Given this list of marker genes BNC1, HLTF (NCBI Gene Id 6596), MYBL1, RAB25, PPARA (NCBI Gene Id 84730), NEUROD1, HOXC9, HOXD12, NEUROG1, NFIL3, VAX1 (NCBI Gene Id 196056), FOXC1, ANKRD1, HOXB3 (homeobox B3), HOXA3, HOXA6, ELF5, NFIA, NR4A2, DPPA2, VDR, EBF1, CLIP2, SIM2, RAB1A, HOXB4, SIX4, GCM2, MEF2B, HOXA13, MYF5, SMAD3, MEF2C, TRPC4, ID3, HNF1B, HMGA2, CUX1, here is a description of the gene set: Selected genes down-regulated in the TLX1 Tet On iEBHX15-4 cells (pro-erythroblasts) at 6 h time point. studied in species Mus musculus Aberrant expression of the human homeobox-containing proto-oncogene TLX1/HOX11 inhibits hematopoietic differentiation programs in a number of murine model systems. Here, we report the establishment of a murine erythroid progenitor cell line, iEBHX1S-4, developmentally arrested by regulatable TLX1 expression. Extinction of TLX1 expression released the iEBHX1S-4 differentiation block, allowing erythropoietin-dependent acquisition of erythroid markers and hemoglobin synthesis. Coordinated activation of erythroid transcriptional networks integrated by the acetyltransferase co-activator CREB-binding protein (CBP) was suggested by bioinformatic analysis of the upstream regulatory regions of several conditionally induced iEBHX1S-4 gene sets. In accord with this notion, CBP-associated acetylation of GATA-1, an essential regulator of erythroid differentiation, increased concomitantly with TLX1 downregulation. Coimmunoprecipitation experiments and glutathione-S-transferase pull-down assays revealed that TLX1 directly binds to CBP, and confocal laser microscopy demonstrated that the two proteins partially colocalize at intranuclear sites in iEBHX1S-4 cells. Notably, the distribution of CBP in conditionally blocked iEBHX1S-4 cells partially overlapped with chromatin marked by a repressive histone methylation pattern, and downregulation of TLX1 coincided with exit of CBP from these heterochromatic regions. Thus, we propose that TLX1-mediated differentiation arrest may be achieved in part through a mechanism that involves redirection of CBP and/or its sequestration in repressive chromatin domains. Human Gene Set: RIZ_ERYTHROID_DIFFERENTIATION_6HR from publication Riz I, Akimov SS, Eaker SS, Baxter KK, Lee HJ, Mariño-Ramírez L, Landsman D, Hawley TS, Hawley RG (PMID 17213805)